Given this list of marker genes Sf3b2, Tprg1l, Ube2k (NCBI Gene Id 53323), Efemp1, Tbcb, Krt14, Bgn, Ly6d, Rpsa, Pnrc1, Slc25a3, Fmnl1, Hspb1 (heat shock protein 1), Ppp1r11, Atg101, Zfp36, Mxra8, Col3a1, Rpl13a, Atp5f1d, Krt15, Ece1, Psmc4, Gng10, Vasp, Ccdc124, Hcls1, Basp1, Cadm1, Ubb, Ldhb, Nudc, Phb2, Exosc5, Dtnbp1, Rbm42, Ctsz, Srsf5 (serine and arginine-rich splicing factor 5), Srsf9, Swi5, Eif3f, Gapdh, Serpinf1, Htra1, Ckb, Csf2ra, Emd, Nsd3, Sod2, Cotl1, Tmsb10, Spag7, Gpc3, Gnb1, Scamp3, Ptp4a2, Fstl1, Pim1 (NCBI Gene Id 18712), Rpl3, Rps7, Ptpn1, Nfkbia, Ctsb, Dusp3, Ostc, Tle5, Laptm4a, Prdx5, Bcl7c, Tnfrsf1a, Csk, Scp2, Lamtor1, Bcl3 (NCBI Gene Id 12051), Crip2, Zfp703, Ehd1, Cd8b1, Sparcl1, Igsf3, Plpp3, Ccdc80, Cxcl10, Mmp2, Ap2s1, H2-DMb1, Calm2, Limd2, Smim14, Crlf2 (NCBI Gene Id 57914), Ctdnep1, Il1b, Islr, Lgals3, Ebf1, Dpysl2, Map1lc3a, Lum (lumican), Pin1, Rexo2, Gsn, Dmkn, Ptms, Krt5, Txn2, Gja1, Rcn1, Cxcl13, Arl8a, Rbm25, Vps37b, Ubl7, Rps3a1, Sparc (secreted acidic cysteine rich glycoprotein), Snrpa, Dcn, Cox5a, Psd, Gadd45b, Snx20, Cd9, Ubb-ps, Ywhae, Serbp1, Gltp, Eif4e, Cd79b, Spr, S100a8, Map2k2, Clu, Zfand5, Fth1, Ezr, Lmo4, Rpl4 (NCBI Gene Id 67891), Apoe, Clic4, Efhd2 (NCBI Gene Id 99974), Cdkn1a, Tacstd2, Dnaja1, Anapc11, Snrpc, Fyb1, Prelid1, H2-Aa, Pkm, Pfdn2 (NCBI Gene Id 18637), Naa10, Tmem160, Aebp1, Drap1, Emc10, Serping1, Gpsm3, Sh3bp1, Eif3h (eukaryotic translation initiation factor 3, subunit H), Creld2 (cysteine-rich with EGF-like domains 2), Nr4a1, Eif5a, Col1a2, Rnaset2b, Gpx3, Pdia6, Tagln2, Inmt, Cyba (NCBI Gene Id 13057), Col6a2, Col6a1, Hsd17b12, Arpc4, Sdhc, Csf2rb, Jtb, Htra3, Rpl13, Rsrc2, H2-K1, Ranbp1, Mgp, H2-D1, Yif1b, Tmed9 (NCBI Gene Id 67511), Hmgn2, Cd34, Scand1, Dpt, Olfml3, Wbp2, Ybx1, Cfdp1, Erp29, Kdm6b, Cxcl1, Atp6v0c, Rrp1 (ribosomal RNA processing 1), Pebp1, Pfn1, Rbm3, Cxcl2, Grb2, Rab5c, Ftl1, Rps3 (NCBI Gene Id 52418), Clec3b, Cdv3, Retnlg, Bri3, Hmgn1, Ifitm2, Reep5, Ebi3, Ier2, Ly6a, Psmb9, Eif3k, Lrrfip1, Chmp2a, Ccnd2, Rab1b, Myl12a, Furin, Id3, Tomm6, Mospd3, Psmd4, Arhgdia, Gga1, Smoc2, Fbn1, Max, Tra2a, Nfe2l2 (nuclear factor, erythroid derived 2, like 2), Nabp2, Jund, Kmt2b, H2-Ab1 (histocompatibility 2, class II antigen A, beta 1), Fis1, Capzb, Arpc3, Prr13, C1s1, S100a9, Fbln1, Cdc37, Emc4, Cfl1, Rplp0, Mfap5, Dhrs4, Rack1, Tkt, Cmip, Has1, Fxyd5, Sdc4, Hsp90ab1, Oaz1, Arpc1b, Calm1, Npm3, Ube2m, Hilpda, Nid1, Apbb1ip, Commd10, Csnk2b, H3f3b, Rheb, Entpd2, Babam1, Samm50, H1f2, Selenow, Hnrnpd, Ifi35, Raly, Igfbp7, Spon2, Mrtfa, Ppp1r2, Col1a1, Ptma, Cdc123, Tex261, Ssbp4, Aup1, Mlf2 (NCBI Gene Id 58874), Clec4a1, Arrb2, Klf13, Ccn1, Etfb, Nfkbib, Samd4b, Clic1, Tgm2, Fam89b (family with sequence similarity 89, member B), Bsg, Shisa5, Kpna4, Cbfa2t3, Hnrnpa0, Tmem119, Pold4, Eno1b, Dpep1, Spi1, Set, here is a description of the gene set: studied in species Mus musculus Mouse Gene Set: TABULA_MURIS_SENIS_GONADAL_ADIPOSE_TISSUE_MYELOID_CELL_AGEING from publication Tabula Muris Consortium (PMID 32669714)